The following is a description of a gene set: Shigella IpgB1 to ITGA/B-RHOG-RAC signaling pathway. Pathway ID: N00952. Pathway type: Pathogen. Pathway class: nt06135 Cytoskeletal regulation (viruses and bacteria). Pathway Definition from KEGG: IpgB1 -> (DOCK1+ELMO) -> RAC1 Human Gene Set: KEGG_MEDICUS_PATHOGEN_SHIGELLA_IPGB1_TO_ITGA_B_RHOG_RAC_SIGNALING_PATHWAY species: Homo sapiens, and this is the list of marker genes: ELMO1, ELMO3, ELMO2, DOCK1, RAC1 (Rac family small GTPase 1)